The following is a description of a gene set: Human Gene Set: REACTOME_NFE2L2_REGULATING_ANTI_OXIDANT_DETOXIFICATION_ENZYMES NFE2L2 regulating anti-oxidant/detoxification enzymes species: Homo sapiens, and this is the list of marker genes: NQO1, HMOX1, SRXN1, ATF4, CREBBP (NCBI Gene Id 1387), PRDX1, EP300, BACH1, GSTA1, SOD3, SLC7A11, MAFK, TXN, TXNRD1, GCLM, NFE2L2, GSR, GSTA3, GCLC